Given this list of marker genes BBIP1 (NCBI Gene Id 92482), TBCD, RASA1, HES7, GBE1, PLP1, MAP3K7, BBS12, CHRNA3, HPS6, MNX1, BBS10, MTFMT (mitochondrial methionyl-tRNA formyltransferase), VANGL1, MKS1, LIG3, EN1, CEP85L, FBXO7, ARL6, CHCHD10, TTC8, LZTFL1 (NCBI Gene Id 54585), BBS5, ELOVL1, COG5, SCAPER, CISD2, ATP13A2, WFS1, CFAP418, ACER3, ERCC6, NOTCH3, IFT27, TRIM32, GJA1 (gap junction protein alpha 1), ARNT2, CLCN6, MARS2, ATXN3, IFT74, VPS11, TBCK, MACF1, BBS2, PPOX, TRAPPC12, PEX3, WDPCP, SDCCAG8, BBS7 (NCBI Gene Id 55212), CEP290, MKKS, NPHP1, IFT172, BBS4, FARS2, GNB1, ERCC8, CEP19, COG7, SNCA, BBS1, BBS9, SCLT1, EPHB4, here is a description of the gene set: A type of bladder dysfunction caused by neurologic damage. Neurogenic bladder can be flaccid or spastic. Common manifestatios of neurogenic bladder are overflow incontinence, frequency, urgency, urge incontinence, and retention. studied in species Homo sapiens Human Gene Set: HP_NEUROGENIC_BLADDER Neurogenic bladder